Given this list of marker genes QDPR, PTS, NR4A2, HPD, SPR, MPV17, TFAM, SLC25A13, BCS1L, PAH, FAH, IMPDH2, GCH1, PCBD1, FTCD, KYNU, PNPO, TAT, TDO2, here is a description of the gene set: Human Gene Set: HP_ABNORMAL_CIRCULATING_AROMATIC_AMINO_ACID_CONCENTRATION Abnormal circulating aromatic amino acid concentration studied in species Homo sapiens Any deviation from the normal concentration of a aromatic amino acid in the blood circulation.